Given this list of marker genes Npy6r, Npy5r, Npy2r, Npy1r, Npy4r, here is a description of the gene set: Mouse Gene Set: GOMF_PEPTIDE_YY_RECEPTOR_ACTIVITY Combining with gut peptide YY to initiate a change in cell activity. studied in species Mus musculus